The following is a description of a gene set: Genes down-regulated in cells (myoblast) by IGF1 vs PDGFB. from publication Kuninger D, Kuzmickas R, Peng B, Pintar JE, Rotwein P (PMID 15475267) Peptide growth factors regulate cell fate by activating distinct signal transduction pathways that ultimately influence gene expression. Insulin-like growth factors (IGFs) play central roles in controlling somatic growth and participate in skeletal muscle development and regeneration. In cultured muscle cells, IGF action is critical both for maintaining viability during the transition from proliferating to differentiating myoblasts and for facilitating differentiation. By contrast, platelet-derived growth factor (PDGF) can sustain cell survival but inhibits differentiation. Here we examine the genetic programs that accompany IGF and PDGF action in myoblasts. Through analysis of high-density oligonucleotide arrays containing approximately 36,000 mouse probe sets, we identify 90 transcripts differentially induced by IGF-I, including 28 muscle-specific genes and 33 previously unannotated mRNAs, and 55 transcripts specifically stimulated by PDGF, including 14 unknowns. Detailed study of one IGF-induced mRNA shows that it encodes a protein related to a recently characterized repulsive guidance molecule postulated to regulate neuronal targeting during development. Our results demonstrate the power of transcriptional profiling for gene discovery and provide opportunities for investigating new proteins potentially involved in different aspects of growth factor action in muscle. studied in species Mus musculus Human Gene Set: KUNINGER_IGF1_VS_PDGFB_TARGETS_DN, and this is the list of marker genes: DUSP6, MMD, F2R, IL33, DLX3, CLBA1, ERRFI1, FBXO32, CSF2RB, CDKN2D, ATP1A3, TIMP1, SLC37A3 (solute carrier family 37 member 3), EPS8, ANXA8L1 (annexin A8 like 1), SPRR1A, SPAG5, IL1R1 (NCBI Gene Id 3554), ANLN, JADE2, NCEH1 (neutral cholesterol ester hydrolase 1), B3GNT2, LBH, ADO, PRKG2, PLXDC1, PTGS1, CENPH, HMGA2, DUSP4, RCAN2, GREM1, CPED1, GFOD1, CAV2, RBPMS, CKAP2L, MGP, THBD, ARHGAP6, SMIM36, CD53, F3, PHEX, TPX2, THBS2